Given this list of marker genes CTNNA1, VAV1, M, MLST8, CAV1, JUP, TRIB3, PDPK1, PRR5, RICTOR, PAK1, CTNNB1, CDH5, MAPKAP1, AKT2, NOS3, MTOR, CALM1, N, AKT3, VAV3, THEM4, PAK2, PAK3, HSP90AA1, CTNND1, RAC1, VAV2, AKT1, here is a description of the gene set: part of: VEGFA-VEGFR2 Pathway Reactome Pathway: VEGFR2 mediated vascular permeability The free radical nitric oxide (NO), produced by endothelial NO synthase (eNOS), is an important vasoactive substance in normal vascular biology and pathophysiology. It plays an important role in vascular functions such as vascular dilation and angiogenesis. NO has been reported to be a downstream mediator in the angiogenic response mediated by VEGF, but the mechanism by which NO promotes neovessel formation is not clear (Babaei & Stewart 2002). Persistent vasodilation and increase in vascular permeability in the existing vasculature is observed during the early steps of angiogenesis, suggesting that these hemodynamic changes are indispensable during an angiogenic processes. NO production by VEGF can occur either through the activation of PI3K or through a PLC-gamma dependent manner. Once activated both pathways converge on AKT phosphorylation of eNOS, releasing NO (Lin & Sessa 2006). VEGF also regulates vascular permeability by promoting VE-cadherin endocytosis at the cell surface through a VEGFR-2-Src-Vav2-Rac-PAK signalling axis. species: Homo sapiens